The following is a description of a gene set: Human Gene Set: MIR214_5P species: Homo sapiens Genes predicted to be targets of miRBase v22 microRNA hsa-miR-214-5p in miRDB v6.0 with MirTarget v4 prediction scores > 80 (high confidence targets). from publication Chen Y, Wang X (PMID 31504780), and this is the list of marker genes: TFDP1, ANKRD65, KLF5, IQSEC3, JAG1, WFDC13, SAE1, CRY2, CNTF, ELAVL4, PPL, RTL9, PREP, PYGO2-AS1, ARHGAP28, UBE2K, RPS6KC1, BPGM, UNC5A, SMAD4, F10, GATA5, KLF8, SRP72, SLC46A3, LRRC75A, NCOA2, KDM2A, NELL2, ZNF704, MAP7D2, KLF12, PGS1, GCNT4, EGFLAM, ADCY6, PSD3, YEATS4, DHX8, FEM1C, ARSB, SOX4, NCKAP1L, ZFP3 (NCBI Gene Id 7537), NXF1, FASLG, AWAT1, DZIP1, ASB4, EYA1, VPS37C, ZNF562, SNAPC5, RLIG1, STK35